Given this list of marker genes Cyp4a12a, Cyp4a30b, Cyp4f15, Cyp4f14, Cyp4a31, Cyp4a29, Cyp4a32, Cyp4a12b, Cyp4f18, Cyp4a14, Cyp4a10, here is a description of the gene set: studied in species Mus musculus Catalysis of the reaction: octane + reduced rubredoxin + O2 = 1-octanol + oxidized rubredoxin + H2O. Mouse Gene Set: GOMF_ALKANE_1_MONOOXYGENASE_ACTIVITY